The following is a description of a gene set: Human Gene Set: GOMF_RNA_STEM_LOOP_BINDING studied in species Homo sapiens Binding to a stem-loop in an RNA molecule. An RNA stem-loop is a secondary RNA structure consisting of a double-stranded RNA (dsRNA) stem and a terminal loop., and this is the list of marker genes: DAZAP1, DDX3X, EIF4A3, RC3H1, FMR1, DHX9, METTL16, LARP6, EPRS1, RC3H2, DDX56, ARID5A, CSDE1, CPEB3 (cytoplasmic polyadenylation element binding protein 3), ZC3H12A, MYH10